The following is a description of a gene set: species: Mus musculus Genes predicted to be targets of miRBase v22 microRNA mmu_miR_874_3p in miRDB v6.0 with MirTarget v4 prediction scores > 80 (high confidence targets). Mouse Gene Set: MIR_874_3P from publication Chen Y, Wang X (PMID 31504780), and this is the list of marker genes: Kcns2, Cntnap2, Msrb3, Sema3f, Usp31, Lmtk2, Psd3, Nudt15, Htr2c, Bclaf3, Shpk, Slc2a4, Rd3, Strn, Sprr2a1, Fbxo33, Sprr2a3, Nr2c2, Arpp21, Sprr2b, Fmr1, Arid3a, Ppfia2, Arrb1, Ppp1r9b, Camk1d, Trappc5, Trps1, Prdm1, Lin9, Slc12a5, Usp8, Sprr2a2, Pgap3, Gid4, Tef, Kdm4a (lysine (K)-specific demethylase 4A), Ankrd44, Ppp1ca, Skint10, Cacnb2, Arhgap39, Sort1, Brd10, Slc6a18, Ndst1, Satb2, Inava, Ikbke, Sirt4, Fhip2a, Brdt, Ptpn12, Srpk1, Borcs8, Nos1